Given this list of marker genes Ndufaf2, F2, Ghrl (NCBI Gene Id 80454), Pparg (peroxisome proliferator activated receptor gamma), C1qtnf12, Exoc3l, Cckar, Il6, Car2, Abca1, Sox4, Npy2r, Cpe, Hif1a, Trpc1, C2cd2l, Vip, Tcf7l2, Snx19, Rbm4, Ffar1, S100a8, Gcg, Abcc1, Efna5, Mir410, Agt, Prkce, Slc9b2, Abcg1, Jak2, Clock, Nr1d1, Fkbp1b, Cela2a, Aacs, Ifng, Acsl4, Aimp1 (NCBI Gene Id 320948), Trpa1, Sct, Sybu, Gper1, Abcb9, Adcyap1, Mtnr1b, Ptger4, Tunar, Lep, Sstr5, Capn10, Tfap2b, Srebf1, Prkd1, Ucn3, Mfsd1, Rab11b, Cltrn, Mup4, Ccn3, Cd74, Abcc5, Oxct1, Gna11, Chga, Drd2, Hmgn3 (NCBI Gene Id 94353), Serp1, Pde3b, Dynll1, Tnf, Gnao1, Slc2a2, Slc8b1, Ffar2, Prkar1a, Tm7sf3, Pex5l, Mcu, Slc18a2, Clcf1, Fam3b, Abcb10, Pclo, Ffar4, Trpm4, Slc15a2, Slc30a8, Trpv4, Trh (NCBI Gene Id 22044), Bad, Slc25a39, Il1b, Gabbr1, Slc16a10, Itsn1, Pfkfb2 (NCBI Gene Id 75925), Tnfsf11, Pck2, Kcnj6, Bglap2, Il1rn, Nnat, Ptpn11, Irs1, Midn (NCBI Gene Id 70193), Glp1r, Dgat1, Edn1, Sidt2, Prkn, Gip, Foxo1, Mlxipl, Brsk2, Adra2a, Nherf1, Abcc2, S100a9, Ano1, Irs2, Nr1h4 (nuclear receptor subfamily 1, group H, member 4), Abat, Vsnl1, Rasl10b, Mafa, Ffar3, Orai1, Mir200a, Ghrhr, Slc13a3, Nos1, Nadk, Baiap3, Crhr2, Kalrn, Fto, Slc15a4, Rfx3, Lrp5, Gprc6a, Ube2q1, Nlgn2, Myt1, Pde8b, Mtnr1a, Gnaz, Gnas, Inhbb, Myrip, Psmd9, Tbc1d1, Oga, Eipr1, Atg7, Pax8, Tap2, Slc16a2, Ncoa6, Stx4a, Crh, Blk, Rab11fip2, Raf1, Ptpmt1, Pfkl, Plcb1, Gpr68, Fam3d, Lepr, Ecrg4, Acvr2b, Sirt3, Cdk16, Egfr, Sri, Nos2, Stxbp5l, Mup1, Sirt1, Uqcc2, Arrb1, Snord35a, Slco3a1, Disp1, Arhgef7, Htr2c, Ghrh, Trpm5, Casr (calcium-sensing receptor), Hfe, Hmga2, Cckbr, Glud1, Cask, F2rl1, Hnf1b, Gck, Slco1b2, Klf7, Nmu, Gpr119, Slc22a8, Sirt6, Hmgcr, Ppp3cb, Rbp4, Crhr1, Kif5b, Piwil4, Rfx6, Gja1, Hmga1, Hnf4a, Rest, Fam3a (FAM3 metabolism regulating signaling molecule A), Prkcb, Nkx6-1, Prkaca, Abcc8, Sytl4, Trpv1, Cplx3 (NCBI Gene Id 260379), Vgf, Pfkm, Snord33, Pde4c, Cacna1e, Pick1, Tfr2, Snap25, Birc5, Ppp3ca, Npff, Cacna1d, Abca12, Glul, Neurod1, Anxa7, Lif, Mup2, F2rl2, Mup3, Slc15a1, Aqp1, Fgg, Ptprv, Doc2b, Foxa2, Rims2 (NCBI Gene Id 72660), Adcy5, Pde1c, Smpd3, Stx1a, Tcirg1, Rab3a, Ccdc186, Mmp7, Gpr39, Abcc4, Osbp, Mir130a, Ucn, Cwh43, Fgb, Hadh, Pdx1, Rab1a, Snord32a, Nr0b2 (NCBI Gene Id 23957), Dio2, Mup5, Stxbp4, Eny2, Jagn1, Lrp1, Cd38, Gpld1, Smad2, Tardbp, Ptbp1, Rab8b, Zbed6, Kcnq1, Ensa, Cnr1, Acvr1c, Syt7, Nucb2, Kiss1, Camk2n1, Rab11fip5, G6pc2, Mup11 (major urinary protein 11), Slc15a5, Ptprn2, Pim3, Rac1, Cdh17, Ppard (peroxisome proliferator activator receptor delta), Isl1, Sirt4, Lrrc8a, Ptger3, Tap1, Tiam1, Gipr, Chd7, Myh9, Slc7a11, Cyb5r4 (cytochrome b5 reductase 4), Trpm2, Htt, Hcfc1, Ptprn, Hnf1a, Slc15a3 (solute carrier family 15, member 3), Cartpt, Grp, Stxbp3, Map4k4, Rapgef4, Cftr, Selenot, Ildr2, Edn3 (NCBI Gene Id 13616), Ccl5, Gnaq, Slc25a22, Anxa5, Park7, Epha5, Pla2g6, Slc25a40, Fbn1, Cpt1a, Snord34, Tacr2, Rptor, Syt9, Fga, Mpc2, Chrm3, Mc4r, Madd, Adcy8, Kcnb1, Mgst1, Apln (NCBI Gene Id 77874), Sfrp1, Pask, Cplx1, Adora1, Slc26a6 (NCBI Gene Id 171429), Per2, Ghsr, Crhbp, Ucp2, Itpr1, Anxa1, Slc16a1, Alox5, Myo5a, Cacna1c, Gnai1, Ildr1, Kcnj11, Stim1, Gpr27, Rph3al, Uts2, Bmal1, here is a description of the gene set: Mouse Gene Set: GOBP_PEPTIDE_TRANSPORT The directed movement of peptides, compounds of two or more amino acids where the alpha carboxyl group of one is bound to the alpha amino group of another, into, out of or within a cell, or between cells, by means of some agent such as a transporter or pore. studied in species Mus musculus